Given this list of marker genes RRM2, CDK1 (cyclin dependent kinase 1), CDC20, FGF22, BUB1, MON2, ACVR2B, BPTF, TADA2A, LINC01010, NSD2, ENSG00000275616, KRT35, TOX4, ZBTB6 (zinc finger and BTB domain containing 6), ANLN, FKBP5, CASP14, DEPDC1, CCDC148, SLC12A1, XAGE3, KIF11, TBC1D8-AS1, TTK, ASPM, NUP50, C4orf46, AURKA, GALT, KIF14, MND1, CENPE, CPNE6, BRCA2, NRTN, SNHG26 (NCBI Gene Id 109729180), HSPH1, FANCD2, SMYD3-IT1, ANKRD50, TUBD1, MAP4K2 (NCBI Gene Id 5871), KIF4A, TTC9B, DNA2, DLGAP5, RIF1, NPNT, H4C12, ZFAND4, FOXM1, KBTBD8, DBF4, FBXL20 (F-box and leucine rich repeat protein 20), CENPA, H3C7 (H3 clustered histone 7), EP300-AS1, FAM72C, RAD54B, LRRC58, HELLS, CD151, SETMAR (SET domain and mariner transposase fusion gene), DIAPH3, FBXO5, GINS3, SPC25, MKI67, SIX3 (NCBI Gene Id 6496), PLK1, GTSE1, RTP1, NDC80, SAMM50, KIF20A, CDC6, PLK4, TP63, ACACA, FAM83D, TFRC, NFIA (NCBI Gene Id 4774), SGO2, ZNF628-DT, PCBP1-AS1, TCEAL3, G3BP1, CCNB1, RAD1, CKAP2L, NCAPH, FUS, CENPF, ECT2, ARHGAP11A, APBB1, B4GALNT3, TSBP1, TNRC6A, CCNA2, CHAF1A, CKS1B, GNAQ, RANBP1, CEP55, HMMR, BUB1B, CFL2, ERCC6L, FAM181B, DCP2, ITPRID1, FAP, MIR4435-2HG, PRKCQ-AS1, BIRC5, SCD, FETUB, POLE2, USP29, DLEU2, KCNA1, TAF5, MIR3939, TOP2A, DEPDC1B, SURF1, LIN28B, TACC3, CDKN3, VSNL1, MEX3C, MYBL2, DSCAM, SHCBP1, PRC1, TMEM107, AURKB, here is a description of the gene set: from publication O'Donnell KA, Yu D, Zeller KI, Kim JW, Racke F, Thomas-Tikhonenko A, Dang CV (PMID 16508012) Overexpression of transferrin receptor 1 (TFRC1), a major mediator of iron uptake in mammalian cells, is a common feature of human malignancies. Therapeutic strategies designed to interfere with tumor iron metabolism have targeted TFRC1. The c-Myc oncogenic transcription factor stimulates proliferation and growth by activating thousands of target genes. Here we demonstrate that TFRC1 is a critical downstream target of c-Myc. Using in vitro and in vivo models of B-cell lymphoma, we show that TFRC1 expression is activated by c-Myc. Chromatin immunoprecipitation experiments reveal that c-Myc directly binds a conserved region of TFRC1. In light of these findings, we sought to determine whether TFRC1 is required for c-Myc-mediated cellular proliferation and cell size control. TFRC1 inhibition decreases cellular proliferation and results in G1 arrest without affecting cell size. Consistent with these findings, expression profiling reveals that TFRC1 depletion alters expression of genes that regulate the cell cycle. Furthermore, enforced TFRC1 expression confers a growth advantage to cells and significantly enhances the rate of c-Myc-mediated tumor formation in vivo. These findings provide a molecular basis for increased TFRC1 expression in human tumors, illuminate the role of TFRC1 in the c-Myc target gene network, and support strategies that target TFRC1 for cancer therapy. Human Gene Set: ODONNELL_TFRC_TARGETS_DN Genes down-regulated in P493-6 cells (B lymphocyte, Burkitt's lymphoma model) upon knockdown of TFRC by RNAi. studied in species Homo sapiens